The following is a description of a gene set: from publication Ochiai K, Maienschein-Cline M, Simonetti G, Chen J, Rosenthal R, Brink R, Chong AS, Klein U, Dinner AR, Singh H, Sciammas R (PMID 23684984) Temporal analysis of B cell activation in vitro using CD40L and IL-2/4/5 cytokines in wild type Irf4+/+ B cells or in mutant Irf4-/- B cells harboring a tet-inducible allele of Irf4. IRF4 expression was restored, or not, in the Irf4-/- background by culturing in the presence of low or high concentrations of doxycycline. The results provide insight in the role of IRF4 expression levels in coordinating different programs of B cell differentiation. Human Gene Set: GSE46606_DAY1_VS_DAY3_CD40L_IL2_IL5_STIMULATED_BCELL_UP Genes up-regulated in CD40L and IL-2 IL-4 IL-5 stimulated at day 1 B cell wildtype versus CD40L and IL-2 IL-4 IL-5 stimulated at day 3 B cell wildtype. species: Homo sapiens, and this is the list of marker genes: KCTD17, TEX26, MRPL45P2, GEM, CCDC7, C12orf76, CYP3A43, ERCC6, ZNF543, CTNND2, MYH2, NCOA4, DAOA, EBF2, KANK2, OLIG1, XDH, CHRM1, ENDOV, ROGDI, GABARAPL3, FSTL4, VGLL1, C5orf47, THSD7A, BCL11A, GRM6, DLG3, TRIML1, ZNF473, LINC02731, CXCL10, PRR7-AS1, ZNF671, TTYH2, CTDSPL, FOXG1, TOB1, NAALAD2, NR2E3, VTN, LINC01085, GNRH1, SHCBP1L, CNTNAP1, GAB3, PLK2, GOLPH3L, PSIP1, MTARC1, CREBL2, A4GALT, TAMALIN, CCDC163, DNASE2 (NCBI Gene Id 1777), GPR68, TREX1 (three prime repair exonuclease 1), PLCXD2, UNC13C, PIK3CD, DNAJB8-AS1, ATP10B, TXNIP, TES, DRD5, LYST, CXorf51A, ERG, ZFHX3, SLC9A9, CCDC172, RBPJ, BTN2A2 (butyrophilin subfamily 2 member A2), CEP126, CTTNBP2NL, FCGBP, CIITA, PDE3B, MAB21L1, SPIN2A, SYNE3, NCF2, FOXP1, HBP1, IL7R, SLC23A1, PMPCB, VCAM1, DGKI, BCL2, ZNF670, MAML2, SIM2, CECR9, NEK2-DT, GOLGA7B, EPX, RDUR, LINC00205, TENM4, SYT1, KCNMB3, TMEM125, MARK2P21, PDPN, EIF4E3, PLEKHA2, FARS2, TEX35, OFD1, ODAM, TMEM154, MANBA, ARL4C, LINC00926, OR8G1, WNT5A, C14orf132 (NCBI Gene Id 91813), UGT3A1, FHDC1, ART1, PSG5, P2RY8, MARVELD2, GAPDHS, F12, METTL21A, MYOM1, DENND4A, ITCH, NR3C1, CERS3, PLA2G12B, AKR1C3, GLCCI1, VEGFC, ABCC6, VASH2, MLH1, SLC19A4P, MEST, DENND5A, SPMAP1, DNTT, TSC22D1, KCNQ1, UTY, FZD2, TNMD, LPIN1, SEL1L3, RNF20, P2RY11, FBXO16, SYNGAP1, STAU2-AS1, PPP1R17, RDM1, AQP9, IRAG2, LRP2, IL19, PPP2R2C, SERTAD4-AS1, FAM83A, ID2B, DEPTOR, IFT88, TPPP2, ATXN1, KLK14, LMO7DN, DLGAP2-AS1, SLC4A8, FXYD1, AKR1C1, TTTY6, RPA1, SCGB1A1, REG1CP, HESX1, OBSCN-AS1, HAO2, CAPN14, ZBTB8B, ITGA2, BCL11B, SCAMP1-AS1, IRS2, SLC24A1